Given this list of marker genes SH3BP5, GIMAP7, SETBP1, BIRC3, LTB, RBPMS, EBF3, ICAM1, GUCY1A1, VNN1, TMEM200A, LGALSL, GIMAP2, FCMR, MMRN1, MEF2C, GIMAP6, EVI2A, HLF, CD34, HOPX, SLC38A1, EFCC1, HECA, PCDHGA10, ABCC2, GSAP, FBXO21, SLC37A3, here is a description of the gene set: species: Homo sapiens Genes up-regulated in LSC (leukemic stem) cells compared to LPC (leukemia progenitor) cells from AML (acute myeloid leukemia) tumor samples. from publication Gentles AJ, Plevritis SK, Majeti R, Alizadeh AA (PMID 21177505) Human Gene Set: GENTLES_LEUKEMIC_STEM_CELL_UP In many cancers, specific subpopulations of cells appear to be uniquely capable of initiating and maintaining tumors. The strongest support for this cancer stem cell model comes from transplantation assays in immunodeficient mice, which indicate that human acute myeloid leukemia (AML) is driven by self-renewing leukemic stem cells (LSCs). This model has significant implications for the development of novel therapies, but its clinical relevance has yet to be determined.